The following is a description of a gene set: species: Mus musculus Any process that stops, prevents or reduces the frequency, rate or extent of fibroblast apoptotic process. Mouse Gene Set: GOBP_NEGATIVE_REGULATION_OF_FIBROBLAST_APOPTOTIC_PROCESS, and this is the list of marker genes: Pik3ca, Pik3cg, Sfrp1 (NCBI Gene Id 72362), Chd8, Gas6, Ddias, Api5 (apoptosis inhibitor 5), Cfdp1, Sirt1